The following is a description of a gene set: Genes down-regulated in pre B lymphocyte after induction of physiological DNA double-strand breaks (DSB) by RAG2; the changes depend on ATM but not NFKB signaling. from publication Bredemeyer AL, Helmink BA, Innes CL, Calderon B, McGinnis LM, Mahowald GK, Gapud EJ, Walker LM, Collins JB, Weaver BK, Mandik-Nayak L, Schreiber RD, Allen PM, May MJ, Paules RS, Bassing CH, Sleckman BP (PMID 18849970) DNA double-strand breaks are generated by genotoxic agents and by cellular endonucleases as intermediates of several important physiological processes. The cellular response to genotoxic DNA breaks includes the activation of transcriptional programs known primarily to regulate cell-cycle checkpoints and cell survival. DNA double-strand breaks are generated in all developing lymphocytes during the assembly of antigen receptor genes, a process that is essential for normal lymphocyte development. Here we show that in murine lymphocytes these physiological DNA breaks activate a broad transcriptional program. This program transcends the canonical DNA double-strand break response and includes many genes that regulate diverse cellular processes important for lymphocyte development. Moreover, the expression of several of these genes is regulated similarly in response to genotoxic DNA damage. Thus, physiological DNA double-strand breaks provide cues that can regulate cell-type-specific processes not directly involved in maintaining the integrity of the genome, and genotoxic DNA breaks could disrupt normal cellular functions by corrupting these processes. Mouse Gene Set: BREDEMEYER_RAG_SIGNALING_VIA_ATM_NOT_VIA_NFKB_DN studied in species Mus musculus, and this is the list of marker genes: Cpne9 (copine family member IX), 6030400A10Rik, Tnk2, Sspn, Tmem254, Cenpc1 (centromere protein C1), A930015D03Rik, Cited2, Entpd1, A430035B10Rik, Mpzl2, H2-Ab1, Lsm8, Pdxdc1, G6pd2, Cpeb2, Acadl, Dnai2, Kif5b, Irak4, Acp5, Slc4a8, Acad10, Trim30d, C1galt1, Cpt1a, Rnf157, Eya1, H2-M3 (NCBI Gene Id 14991), D2hgdh, Ccdc126, Taf4b (NCBI Gene Id 72504), Bhlhe41, Tgfbrap1, Phka1, Mtdh, Pctp, Cdk5rap1, Pomt1 (NCBI Gene Id 99011), Ank3, Tceal9, Cuedc1, Slc44a1, Esco1